The following is a description of a gene set: Abnormal metabolic brain imaging by MRS species: Homo sapiens Human Gene Set: HP_ABNORMAL_METABOLIC_BRAIN_IMAGING_BY_MRS An anomaly of metabolism in the brain identified by magnetic resonance spectroscopy (MRS)., and this is the list of marker genes: GALC (galactosylceramidase), TBCK, VARS2, MT-ND5, DNM1L, TEFM, NAT8L, LYRM4, GAMT, SDHAF1, ECHS1, MRPL39, MT-TW, MT-TF, POLRMT, IBA57, MT-CO1, ATAD3A, NFU1, FBXO28, CACNA1G, SLC35A2, HSD17B10, LYRM7, SLC6A8, MT-TS2, FARS2, COX16, SQOR, NDUFAF6, SLC25A12, COX11, SDHD, LIPT2, SV2A, MECR, NGLY1, MPV17, PSAP, HPDL (4-hydroxyphenylpyruvate dioxygenase like), POLR3A, MT-TQ, MT-ND1 (NCBI Gene Id 4535), HTRA2, GFM2, SDHB, CNP, GATM, FOCAD, ASPA (NCBI Gene Id 443), MRPS34 (mitochondrial ribosomal protein S34), SUCLG1, NDUFB7, GCSH, ADORA2A, KARS1 (NCBI Gene Id 3735), MT-CO2, FDFT1, COG8, MT-CO3, NAXE, ACAT1, MT-ND4, CYP27A1, FBXL4, MT-TH, MTRFR, GRM7, RPIA, MT-ND6, COQ4, MT-TL1, SLC39A8